The following is a description of a gene set: Human Gene Set: GOBP_NEGATIVE_REGULATION_OF_RNA_CATABOLIC_PROCESS studied in species Homo sapiens Any process that stops, prevents or reduces the frequency, rate or extent of RNA catabolic process., and this is the list of marker genes: NAF1, DAZ4, RBM46, PHAX, PKP1, RNH1, LRPPRC, FAM76B, TENT5C, EIF4ENIF1, METTL14, TENT4A, SLC11A1, RBM24, HNRNPA0, MAPKAPK2, APOBEC1, SLIRP, NICOL1, YBX1, FXR1, PABPC1, TRDMT1, ARID5A, ZC3H14, ZCCHC17, METTL1, A1CF, TRAF2, LARP1 (NCBI Gene Id 91673), TRAF5, TAF15, RBM47, SYNCRIP, THRAP3, DHX9, RBM10, METTL16, LARP1B, TARDBP, DND1 (DND microRNA-mediated repression inhibitor 1), MEIOC, NBAS, TENT4B, UPF3A, ZAR1, FUS, DAZL, ELAVL4, NRDE2, DHX36, PAIP1, PKP3, TENT5A, VIP, IREB2, HNRNPU, IGF2BP3, YBX3, BOLL, E2F1, LARP4B, CSDE1, NSUN2, TENT2, NOCT, TRAF3IP2 (TRAF3 interacting protein 2), MYD88, ANGEL2, PARN, MAPK14, HNRNPD, TOB1, AXIN2, DAZ3, DKC1, IGF2BP2, DAZ2, SRSF1, HNRNPC, ELAVL1, GDNF, TENT5B, RBM38, ZFP36, HNRNPAB, QKI, IGF2BP1, CIRBP, TIRAP, FBLL1, DAZ1, TENT5D, DHX34, IKBKE, SECISBP2